Given this list of marker genes ACSL3, FLNA, ATP2B4, EFR3B, RAPGEF6, IKBKB (NCBI Gene Id 3551), ARHGEF16, AFDN, ROCK1, CAV3, BBS1, SPTBN1, RAP2A, PICALM, MIR223, NSF, SQSTM1, MMP14, ATP6AP1, LYPLAL1, WNK4, VPS4A, SIRT6, C2CD5, GGA2, GCC2, VTI1B, TTC8, PRKCI, STAC3, BSG, SCP2, CLTC, NKD2, RHOG, PKDCC, EXOC5, GOLPH3L, EPHA2, RILPL2 (Rab interacting lysosomal protein like 2), VPS35, SORL1, PALM, PTPN9, NHERF4 (NCBI Gene Id 79849), PIK3R2, SMURF1, SCRIB, ITGB1BP1, STX4, F11R, FLOT1, RILPL1, DPP10, ERRFI1, NSG1, FGF13, FCHO2, ARL6IP5, LGALS3, ROCK2, ITGA3, ADIPOQ, ABI3, PALS1, TREM2, PPP2R5A, EZR, WNK1, PKP2, VAMP2, NUMB, PDZK1, TMEM59, PGRMC1, DLG1, PRNP, TMED2, ACTB, BCL2L1, PACS2, STXBP1, WNK3, TNIK, PRKG2 (NCBI Gene Id 5593), RAB11FIP2, GAS6, GPER1, ABCA12, VAMP4, MRAP, CAMK2G, FYB1, GOLPH3, LAMA5, ZDHHC7, PIGW, ZDHHC5, IFNG, OPTN, SKAP1, PRPH2, TTC7A, VAMP8, PPFIA1, RAMP3, PID1, ZDHHC4, EHD3, FYB2, SCARB2, PKP3, GPR158 (NCBI Gene Id 57512), MRAP2, LRP6, RSC1A1, TESC, KCNB2, GOLGA7, PPP1R9B, RAC1, TMEM150A, AKT2, LRP1, TMEM88, EHD4, CDK5, PDPK1, EPHA3, ATP1B3, ANK2, ANK3, EGFR, RAB8A, P2RY1, CRB3, CAMK2B, LYPD1 (LY6/PLAUR domain containing 1), CD81, TNFRSF1A, PIP5K1A, RAB11FIP3, EPB41L3, TGFB1, NHERF2, KIF5B, RER1, SLC4A1, SYS1, RHOQ, WDR72, TSPAN14, DAB2, VAMP5, APPL1, CSK, CNST, CSRP3, PPIL2, WNT3A, HYCC1, KRT18, VIL1, AMN, ZDHHC3, RAB34, ZDHHC8, CDH2, VAMP3, LDLRAP1, GRIP2, HSP90B1, BAG4, IFT20, FCER1G (NCBI Gene Id 2207), KCNIP3, STX8, ZDHHC2, LARGE1, AP2M1, RDX, STAC2, RAP1A, KCNIP4, GOLGA4, SFN, BBS2, PIK3R1, RAB13, CNPY4, CLN3, PRAM1, STAC, NRXN1, GGA3, MAP7, LYPLA1, ATP1B1, STX7, BLZF1, COMMD1, CAMK2D, GORASP1, MESD, PREPL (prolyl endopeptidase like), RAMP2, LRRC15, PACSIN1, RAB10, SLMAP (NCBI Gene Id 7871), CACNB3, PLEKHF1, FRMD8, TNF, ATP2C2, PACS1, TTC7B, S100A10, AR, ACTN2, PDZK1P1, ZFYVE27, SCN3B, TSPAN33, CIB1, ZDHHC23 (NCBI Gene Id 254887), PKP1 (plakophilin 1), PRKCZ, CLIP3, EFR3A, AKAP5, EPM2A, INS, GRIPAP1, GRIP1, AGR2, TPBG, EHD2, RAB7A, SORBS1, FLOT2, YPEL4, MYO5A, ATP2C1, GBP1, PTCH1, INPP5K, RAMP1, DCHS1, RACK1, STX3 (NCBI Gene Id 6809), CACNB2, RANGRF, SEC23A, RHBDF2, GAK, ZDHHC22, ARHGAP44, GGA1, AKT1, CCDC88A, EPHB2, PRKCH, ITGB1, TMBIM1 (NCBI Gene Id 64114), NECTIN3, NHERF1, KIF13A, GORASP2, RAB26, HYCC2, ARF6 (NCBI Gene Id 63379), MACF1, DENND4C, EMP2, SEC16A, ANK1, CDH1, JUP, RAPGEF2, KCNB1, DPP6, CAMK2A, ARL6, PLS1, EHD1, SPTBN4, RAB31 (RAB31, member RAS oncogene family), ARFRP1, TSPAN15, PRKCE, RAB11A, NHLRC1, LRRC7 (NCBI Gene Id 57554), PHAF1, TSPAN5, ANXA13, TRARG1, here is a description of the gene set: A process in which a protein is transported to, or maintained in, a specific location in the plasma membrane. Human Gene Set: GOBP_PROTEIN_LOCALIZATION_TO_PLASMA_MEMBRANE species: Homo sapiens